The following is a description of a gene set: from publication Tabula Muris Consortium (PMID 32669714) studied in species Mus musculus Mouse Gene Set: TABULA_MURIS_SENIS_AORTA_AORTIC_ENDOTHELIAL_CELL_AGEING, and this is the list of marker genes: Rpl6, H2-K1, Eif1, Sparc, Abcf1, Gng11, Rps3, Bri3, Frg1, B2m, Eef1a1, H2-Eb1 (histocompatibility 2, class II antigen E beta), Dusp3, Abat, Syf2, Dpt, Fabp5, Rps10, Nop53, Klf12, Ptms, Plp2, Ubb, Serpinh1, Bloc1s1, Rplp0, Ltf, Gsn, Smagp, Araf, Fth1, Tnfrsf10b, Zbtb46, Cst3, Rpl4, Pcbp2, Inka1, Oaz1, Ubb-ps (ubiquitin B, pseudogene), Tmem160, Rps11, Krt15, Sncg, Nfic, Aqp7, Rtf1 (RTF1, Paf1/RNA polymerase II complex component), Krt14, Socs2, Ace2, Rps4x, Stmn2, Rpl7, Gstm1, Ptger4, Fosl2, Rps14 (NCBI Gene Id 99773), Csf1r, Metap2, Rpl13a, Arf5, Jund, Vim, Rack1, Pltp, Rpl9, Bsg, Cavin2, Capns1, Peg3, Ier2, Ablim3 (NCBI Gene Id 381172), Map1lc3a, Dnajc8, Kcnj10, Pde4b, Ecscr, Furin, Pnrc1, Ndrg1, Tob1, Rplp1, Mgll, Zfp36l1, Npc2, Vsir, Igfbp7, Dock6, Tuba1c, Ccn1, Ercc1, Arl13b, Junb, Egr1, Zfp369, Edf1 (NCBI Gene Id 80387), Cfl1, Lrrc8a, Gnb2 (guanine nucleotide binding protein (G protein), beta 2), Zbtb34, Apoe, Nr4a1, Zfp36, Atp5f1c, Cebpd, Naca, Anapc11, Ybx3, Csrp1, Sf3b4, Qdpr, H2-Ab1 (NCBI Gene Id 406212), Slc19a1, Babam1, Atf4, Stub1, Fmo1, Ece1, Rps7, Ybx1, Lonrf1, Tmsb10, Actg1, Tmem119, Pabpc4l, Ssbp4, Crip1, Dennd5b, Nmi, Mgp, Eef1b2, Smco4, Psmc3, BC031181, Bin1, Cd63, Rpl8, Nfkbib, Nme2, Rpl3, Ablim1, Rpl14, Pfn1, Egfl7, Ifitm2, Fos, Gpx3, C1qtnf9, Cxcl12, Idh2, Gstt2, Arglu1, Ctnnbip1 (NCBI Gene Id 93799), Tle5, Ppib, Aup1, Dnaja1, H2-Aa, Sparcl1, Sdc4, Des, Rin3, Rhoc, Dynll2, Peg12, Cldn5, Nol7, Mospd3, Srsf2, Rpl29, Tut7, Gapdh, Rnd1, Rwdd1, Rpsa, Myl12a, Ptma, Eeig1, Rpl17, Gnb1, Prnp, Aqp1, Tbrg1, Nras, Ypel3, Sub1, Npm1, Fastkd1, Cav1, Rpl35, Klf4, Stx18, Pabpc1, Tcf15, Ppm1g, Lgmn, Mtarc2, Selenow, Sod1, Csf2rb, Rpl28, Kdm6b, Ppp1r2, Rab5c, Slc28a2, Rnf138, Fabp4, Thbd, Ube2m, Gstm2, Cd36, Znhit1, Arpc3, Rbm26, Dcn, Tnfsf12, Arhgdia, Apold1, Myl12b, Spr, Tmem26, Tmsb4x, Clic1, Rps20, Cltb, Lmo1, Ftl1, Apol10b, Fubp3, Cdh5, Selenom, F11r, Plp1, Cdh13, Mall, Tpm1, Rpl32, Emc10, Tpt1, Meox2, Rp9 (NCBI Gene Id 55934), Rps18, Rbm3, Fip1l1, Eif3f, Ddrgk1, Prr13, Trf (transferrin), Tomm6 (translocase of outer mitochondrial membrane 6), Rps8, Klf13, Ppic, Zfp131, Slc2a5, Rps9, Slc26a10, Tspan4, Rps5, AW112010, Rps3a1, Bltp1, Irgm2, Depp1 (DEPP1 autophagy regulator), Zscan26, Tspan7, Plscr3, Cfh, Btg2, Siglech, Cd79b, Tspan13, Car4, Rpl13, Cpsf1, Drap1, Myct1 (NCBI Gene Id 68632), Prelid1, Gpx4, Dpysl2, Rpl24, Hes1, Ddit4, Ccdc85b, Mcur1 (mitochondrial calcium uniporter regulator 1), Ppp1r11, Lpl, Gadd45g, Cd74, Gpihbp1, Snrpc, Cavin1, Hmg20b, Obscn, Rps24, Cfdp1, Rhob, Tshz3, Ctla2a, Mrtfb, Tgtp2, Klf2, Lasp1, Sdhc